Given this list of marker genes Ctnnb1, Actg2, Ubb, Ctss, Actc1, Il6, Rela, Nfkb1, Cbll1, Il6ra, Acta1, Jup, Tyk2, Cdc42, Cdh1, Rps27a, here is a description of the gene set: species: Mus musculus electronically inferred by orthology from the curated human pathway part of: Adherens junctions interactions Reactome Pathway: Activation of STAT3 by cadherin engagement This event has been computationally inferred from an event that has been demonstrated in another species.<p>The inference is based on the homology mapping from PANTHER. Briefly, reactions for which all involved PhysicalEntities (in input, output and catalyst) have a mapped orthologue/paralogue (for complexes at least 75% of components must have a mapping) are inferred to the other species.